The following is a description of a gene set: studied in species Homo sapiens from publication Billmann-Born S, Till A, Arlt A, Lipinski S, Sina C, Latiano A, Annese V, Häsler R, Kerick M, Manke T, Seegert D, Hanidu A, Schäfer H, van Heel D, Li J, Schreiber S, Rosenstiel P (PMID 21335489) Human Gene Set: GSE22611_NOD2_TRANSD_VS_CTRL_TRANSD_HEK293_MDP_STIM_2H_UP Genes up-regulated in HEK293 cells at 2h after stimulation by muramyl dipeptide: over-expressing mutant NOD2 versus control. NOD2 is an intracellular receptor for the bacterial cell wall component muramyl dipeptide (MDP) and variants of NOD2 are associated with chronic inflammatory diseases of barrier organs e.g. Crohn disease, asthma and atopic eczema. It is known that activation of NOD2 induces a variety of inflammatory and antibacterial factors. The exact transcriptomal signatures that define the cellular programs downstream of NOD2 activation and the influence of the Crohn-associated variant L1007fsinsC are yet to be defined. To describe the MDP-induced activation program, we analyzed the transcriptomal reactions of isogenic HEK293 cells expressing NOD2wt or NOD2L1007fsinsC to stimulation with MDP. Importantly, a clear loss-of-function could be observed in the cells carrying the Crohn-associated variant L1007fsinsC, while the NOD2wt cells showed differential regulation of growth factors, chemokines and several antagonists of NF-κB, e.g. TNFAIP3 (A20) and IER3., and this is the list of marker genes: MAF, BORCS6, SLC5A6, SCRN3 (NCBI Gene Id 79634), ENSG00000291006, OBP2A, KLRC3, ATP2C2, ACADSB, SLC17A4, SLC7A1, SLC35D2, ANGPT2, GSK3A, FHIT, NELL2, PJA1, PUS7L, NR3C2, GNL3LP1, ACSF2, SBNO1, ELF3, WWC1, GDF2, FEZ1, TXNRD3, RALGAPA1 (Ral GTPase activating protein catalytic subunit alpha 1), ARHGEF15, CDH2, HECTD3, CYB5R3, TPSG1, SPAST, ADGRG6, ADAMTS8, PFDN1, EPHX1, OPA1, LRRC37A4P, SOX3, ERBB2, CLCN5, ZSCAN26, CKAP2, ARMCX1, KCNC3, CKB, JPH3, FHL5, HSD17B3, AKR1C3, RSAD1, SSBP1, SEMA6D, RAD54L2 (NCBI Gene Id 23132), MTMR11, INA, MTRR (5-methyltetrahydrofolate-homocysteine methyltransferase reductase), NPY6R, OGG1, HEATR6 (NCBI Gene Id 63897), LY6G6D, DCLK1, CHRNA3, SPHK2, UGT2A3, GPR182, PRKAA1, EHF, ADGRL4, PRND, POLR1F, OR6A2, VPS37A, NR1H4, BAIAP3, TMEM9B, GFAP, FSCN3, OSBPL3, PORCN, CCDC68, AP3M2, IKZF3, SPATA2, NME5, CEACAM7, SUPT3H, APOC2, ZNF154 (NCBI Gene Id 7710), KIF3C (NCBI Gene Id 3797), SKA1, KCNMB1, FBXW11, TEK, LAMB1, SAV1, NSD3, IRS4, BMERB1, MARCHF1, EZH1, WDCP, USP2, NCAM2, GAS2L1, LRRC37A3, SOX11, GID4, CCDC92, H4C9, SRRM2, BICD1, ELK4, ENSG00000274253, PLEKHA1, PSD3, ATG14, JAK3, CA6, MARS1, BPI, GADD45G, USP9Y, PAPOLA, NEB, THTPA, GPR107, TLL2, TAF5L, ATRN, RAB14, NLRP2, UTS2, BFSP2, IMPG2, FZD10, GNG12, BHMT, GSDMB, PREX2, SYT2, TASOR, MYL3, HSPB7, ELF5, TTC27, DENND2A, GPR171, MAGIX, PDK4, MATCAP2, SERPINB4, ADGRB2, CTSW (NCBI Gene Id 8849), CTSK, ASCL3, RORA, ATP1B1, H2AC17, PARG, CPB2, CLCA3P, THSD7A, VPS13B, FSTL1, NKX2-8, ELK3, PODNL1, HCG9, CCZ1B, HOXD3, CD5, PLAC1, HAUS6, ACSBG2, CHRNA1, EMP1, GLI1, SMIM14, OTULINL, SDC2, ABTB2, RAB11FIP3, EOGT, EXOSC2, FCRL2 (NCBI Gene Id 79368), CPN2, MCF2L, LEFTY2, RAD17, KLHL35, CD96, APOC1, TSPYL2